The following is a description of a gene set: Human Gene Set: GOBP_GUANINE_METABOLIC_PROCESS species: Homo sapiens The chemical reactions and pathways involving guanine, 2-amino-6-hydroxypurine, a purine that is one of the five main bases found in nucleic acids and a component of a number of phosphorylated guanosine derivatives whose metabolic or regulatory functions are important., and this is the list of marker genes: PRTFDC1, KDM1A, NT5C2, GDA, HPRT1, XDH